Given this list of marker genes RHOBTB3, KIF18A, GOLIM4, CYTH3, KIF18B, TMED7, USE1, CAPZA2, ACTR10, TRIP11, BNIP1, GOLGA4, COPG2, GOSR2, RAB33B, TUBB4B, TUBA3C, KIF3A, DYNC1H1, IGF2R, COPZ1, COPG1, KIF1B, VPS51, KIF5A, GBF1, KIFC1, TMF1, RAB43, YKT6, KDELR2, ARF1, BICD2, GOSR1, COPE, KIF6, RAB9A, DYNC1I1, KLC3, CUX1, DYNLL2, TMED3, NAA35, TUBB3, NAA38, PAFAH1B1, KIF20A, NAA30, KLC2, STX5, RAB1A, KIF25, MAN1A2, DCTN4, TUBA1B, PAFAH1B2, COPA, GCC2, TUBA1C, RGP1, COG1, RINT1, BICD1, KIF2B, STX10, KIF3B (NCBI Gene Id 9371), VTI1A, AGPAT3, USP6NL (NCBI Gene Id 9712), CYTH2, TUBA1A, GCC1 (NCBI Gene Id 79571), PAFAH1B3, KIF21A, VPS52, TMED2, RAB39A, PLA2G6, KIF9, VAMP4, ACTR1A, DCTN6, KDELR3, KIF4A, TUBA3D, PLA2G4A, GOLGA5, KDELR1 (KDEL endoplasmic reticulum protein retention receptor 1), CYTH1, CENPE, NBAS (NCBI Gene Id 51594), ALPP, COG8, RAB3GAP1, KIF1C, KIF16B, ARL1, TUBA4A, RAB30, COG5, KIF4B, TUBB6 (tubulin beta 6 class V), RIC1, COG7, RAB6A, RAB9B, SCOC, KIF21B, ZW10, RACGAP1, KIF27, TUBB2A, BET1L (Bet1 golgi vesicular membrane trafficking protein like), ARF3, CYTH4, DYNLL1, KIF15, ARF5, NSF, TUBB4A, NAPA, DCTN3, KIF26A, RAB1B, TUBB2B, KIF23 (NCBI Gene Id 981), RAB36, KIF22, KIF1A, TMED10, COG4, CAPZB, KIF13B, SNAP29, MAN2A1, ARFGAP3, TUBA8 (tubulin alpha 8), COG6, NAPG, SEC22B, GALNT2, GOLGA1, KIF19, MAN1C1, KIF12, RABEPK, STX16, KIF3C, RAB3GAP2, KIF26B, KIF5B, ARFGAP1, ARCN1, RAB6B, COPB2, KIF11, NAPB (NCBI Gene Id 63908), ARFGAP2, COG2, DYNC1LI2, CAPZA1, TMED9, COG3, KLC1, STX18, VPS53, KIF20B (kinesin family member 20B), KIFAP3, VPS54, GALNT1, STX6, TUBB8, RAB41, M6PR, PLIN3, ARFIP2, ARFRP1, DYNC1I2, DYNC1LI1, SURF4, DCTN2, MAN1A1, RAB18, TUBAL3, KLC4 (NCBI Gene Id 89953), COPB1, DCTN1, MAN2A2, TUBB8B, VPS45, TUBA4B, ARF4, VAMP3, KIF2C, KIFC2, SYS1, COPZ2, KIF2A, TUBB1, DCTN5, TGOLN2, CAPZA3, TUBA3E, here is a description of the gene set: Human Gene Set: REACTOME_INTRA_GOLGI_AND_RETROGRADE_GOLGI_TO_ER_TRAFFIC Intra-Golgi and retrograde Golgi-to-ER traffic studied in species Homo sapiens